Given this list of marker genes IQSEC3, ERN1, PIK3CA, DZIP1, CHTF8 (chromosome transmission fidelity factor 8), SMAD3, FAM53B, CD99L2, ATP1A3, PENK, GGA3, IQSEC2, RASD2, ANKMY1, WDR48, FAM219A (NCBI Gene Id 203259), PHKG1, ABLIM3, TYR, CDH8, TMEM104, TMCC1, FGF23 (fibroblast growth factor 23), TRIM28, GRAMD1B, GPR137B, GNAZ, SLC25A29, PRELP, ZNF677, DRP2, BCL9L, POLDIP3, CPLX2, TOB2, FBXL5, TIMP3, LOXL3, ESPN, USF2, CYB5RL, PGP, TRIP12, CRTC2, NGFR, GNG13, UBR7, TPPP, SDC3, MTCL2, SLC35F6, RCAN2, POM121, PARL (NCBI Gene Id 55486), ATG7, CSPP1, SDK1, ALPG, TSPAN18, CEACAM19, POM121C, KCNQ2, here is a description of the gene set: Human Gene Set: MIR6845_5P from publication Chen Y, Wang X (PMID 31504780) studied in species Homo sapiens Genes predicted to be targets of miRBase v22 microRNA hsa-miR-6845-5p in miRDB v6.0 with MirTarget v4 prediction scores > 80 (high confidence targets).